The following is a description of a gene set: Human Gene Set: LAKE_ADULT_KIDNEY_C18_COLLECTING_DUCT_PRINCIPAL_CELLS_MEDULLA species: Homo sapiens from publication Lake BB, Chen S, Hoshi M, Plongthongkum N, Salamon D, Knoten A, Vijayan A, Venkatesh R, Kim EH, Gao D, Gaut J, Zhang K, Jain S (PMID 31249312), and this is the list of marker genes: RPL10, RPS13, UBE2D3, TGFBR1, PLCL2, CNBP, CLINT1, RPS4X, GSTM3, METAP2, LITAF (NCBI Gene Id 9516), RPL8, GPX1, PRPF40A, ATP5MC3, RPL6, PRDX1, ARF1, TOP6BL, ADGRG1, RPS20, CALM1, PTGES3, RPS18, ACSL4, RPL31, LLGL2, PRDX6, SPTBN1, GSTP1, TMEM213, GDF15, SCIN, SMARCA5, RHOBTB3, MECOM, SLC16A5, RPS24, ACTG1, HLA-B, RPS23, RSRP1, RPLP1, ATP5F1A, PRKAG2, RPS16, RPS7, EIF4A2, LAMTOR5, CIB1, ST6GAL1, TMSB4X, SLPI, REEP5, MTATP6P1, BTF3, PRKAR1A, SOD2, PIK3C2G, BMPR1B, KRT18, PAPPA, AQP2, CLU, MYO1B, LDHB, KRT8, WFDC2, TMBIM6, KITLG, LDHA, UBXN4, CD24, ACAT1, ANAPC16 (anaphase promoting complex subunit 16), CD46, GNAS, MAL, RPL13, SYTL2, EPCAM, PLSCR1, KAZN, ASAH1, PAPOLA, RPL5, MAL2, MYL12B, PGGHG, SPTBN2, NUCKS1, ALDOA, DYNLT1, KIF5B (NCBI Gene Id 3830), NDRG1, RPL35, FAU, PDE1A, RPS28, STIM2, GATA3, RPL12, TPT1, PDIA3, DUSP6, CYB5A, FUCA1, AIF1L, TMSB10, RTN4, RPS12, TGOLN2, RPL3, RPL9, EEF2, NDUFA4, PDK4, SEC62, PSAP, RPS14, EIF4G2, ARG2, PFKFB3, RPL32, MMP7 (NCBI Gene Id 4316), YWHAZ, FYB2, HLA-A, MAN1A1, PDIA6, CNDP2, CYSTM1, CA12, EID1, RPS2, HSP90AA1, NUPR1, TSPAN1, TXNIP, KTN1, S100A10, ANXA2, CANX, DICER1, RPL7, APLP2, ATP6V1A, PGK1 (NCBI Gene Id 5230), CREM, EIF1, MYL6, ACADVL, ZFP36L1, HSD11B2, SRSF3, BTG2, RALBP1, FXYD4, XRCC5, PLEKHA2, HADHA, YWHAB, GUK1, RPL19, RPS9, HSPD1, EPRS1, GPRC5C, NPM1, RACK1, ARPC2, TOX, IFITM3, SOD1, RPL24, RTN3, RPL4, H3-3B, HSP90B1, RPL21, TPR, RPS15, RPL23, SLC44A1, SGPP1, SEPTIN7, RDH10, RPS8, HLA-C (NCBI Gene Id 5674), RPL13A, EEF1D, ITM2C, RPL11, EEF1A1, HACD3, MGST3, HNRNPA3, RPL10A, CTSH, PCMTD1, HNRNPR, SKIL, GABARAPL1, NACA, S100A6, CSDE1, CD2AP, NORAD (non-coding RNA activated by DNA damage), PKM, DDX5, COX4I1, RPLP0, CCNI, FTL, HSP90AB1, RPS6, RPL18, HNRNPU, TPI1, ACTR2, SEPTIN11, RNF213, TMEM59, ENO1, SLC38A1, DSP, ATP6V0E1, CHCHD2, DUSP1, RPS27A, RPL7A, PFDN5, CA2, KRT19, PABPC1, TACSTD2, HINT1, PTMA, HNRNPA2B1, SERBP1, SARAF, MYO10, RPS25, PTTG1IP, RPL30, PTBP3, FTH1, AQP3, JAK1, CD81, NAP1L1, GAPDH, RPLP2, C12orf75, IFITM2, ATP5F1C, CRYAB, RANBP2, RPS3A, RPS19, RPS11, MNS1, RPL15, PPIA, PWRN1, HNRNPDL, HSPA9, MYH10, LAPTM4A, CD63, THSD7A, TPM4, RPL37A, IQGAP1, RHOA, BEX3, ATP6V1G1, IVNS1ABP, RPSA, MTUS1, SF3B1, COX7C, PLEKHA1, DSTN, SAT1, PTPN13, RPL34, TAX1BP1, RBBP8, FAM107B, SRP14, UBB, PPIB, ATP1B1, MYL12A, SERF2, PCM1, B2M, RASD1, CD164, PEBP1, CCT6A, CD9, RPL14, CXXC5, PSMA7, ID1, ATP5F1B, UBA52, AKR1B1, IGFBP7, IGFBP3, ITM2B, YBX1, BAG1, RPS27, RPS5 (ribosomal protein S5), RPL41, DCDC2, CDH16 (cadherin 16), KCNJ16, ISCU (NCBI Gene Id 91850)